Given this list of marker genes MCM5, BRCA1, MCM2, TERT, LIG1 (DNA ligase 1), MITF, here is a description of the gene set: Reactome Pathway: Regulation of MITF-M-dependent genes involved in DNA replication, damage repair and senescence part of: MITF-M-dependent gene expression species: Homo sapiens MITF target genes are involved in DNA replication, damage repair and chromosome maintenance and stability. Cells depleted of MITF through siRNA can undergo senescence as a result of accumulating DNA damage. In contrast, cells that are depleted of MITF by overexpression of ATF4 undergo reversible cell cycle arrest but do not undergo senescence, suggesting that ATF4 and translational reprogramming may block the senescence pathway.